The following is a description of a gene set: A soft tissue continuity in the anteroposterior axis between the toes 2, 3, and 4. Human Gene Set: HP_2_4_TOE_CUTANEOUS_SYNDACTYLY 2-4 toe cutaneous syndactyly studied in species Homo sapiens, and this is the list of marker genes: DYRK1A, GJA1, CAMTA1, SVBP, SC5D